The following is a description of a gene set: Reactome Pathway: G alpha (i) signalling events species: Homo sapiens The classical signalling mechanism for G alpha (i) is inhibition of the cAMP dependent pathway through inhibition of adenylate cyclase (Dessauer C W et al. 2002). Decreased production of cAMP from ATP results in decreased activity of cAMP-dependent protein kinases. Other functions of G alpha (i) includes activation of the protein tyrosine kinase c-Src (Ma Y C et al. 2000). Regulator of G-protein Signalling (RGS) proteins can regulate the activity of G alpha (i). part of: GPCR downstream signalling, and this is the list of marker genes: CXCL16, PPBP, CAMK2G, TAS2R39, GNB3, TAS2R1, NMU, GNG13, PRKAR2A, GNB5, RGS3, NMS, PPP3CC, PLCB1, GPER1, SAA1, NPBWR2, GAL, CORT, CCR2, C3, PDE1A, CCL1, ADCY4, GPR37, NPBWR1, CCR1, C5AR1, OPRD1, GNG11, TAS2R3 (NCBI Gene Id 50831), GNAI1, NPY4R, PF4, TAS2R4, TAS2R20, GNB2, PDE1C, GNA14, CCL25, NMUR1, TAS2R10, PPP2R1A, CCR6, ITPR1, GNG4, PDE4B, ADRA2C, CCL13, TAS2R31, C5, GRM2, SSTR2, RGS21, RGS9, GNAS, CXCR4, NPY1R, FPR2, GALR2, PRKCG, APP, MCHR2, CCL19, OPN1LW, GPR17 (G protein-coupled receptor 17), CAMK4, PLCB3, GNA11, OPN1SW, GNG8, GPR31, GPR55, CREB1, PENK (proenkephalin), ITPR3, TAS2R16, GNAT1, SSTR1, PRKAR1A, OXGR1, HTR5A, PPP2R5D, GNAI3, AGTR2 (angiotensin II receptor type 2), SSTR3, GRM6, PRKAR1B, FPR1, OPRM1, PPP3CB, LPAR1, TAS2R50, GABBR1, PLCB2, BDKRB1, PRKCA, LPAR3, MTNR1B, S1PR4, CXCR3, RGS19, PDE1B, CALM1, HTR1F, ANXA1, PPY, CCL21, RGS5, RGS16, S1PR5, CXCL12, CXCR5, RGS12, SUCNR1, CX3CL1, SRC, ACKR3 (NCBI Gene Id 57007), PPP2R1B, LPAR5, NBEA, TAS2R45, GNAL, RGS4, HTR1D, GNG10, GRM8, PRKCD, MTNR1A, RGS14, TAS1R3, GPSM2, RGS13, ADCY3, P2RY14, RGS8, CXCR1, NPY, CCL4, RGS17, OPN3, PPP3R1, TAS2R13, SST, RGSL1, PDYN, AGT, RGS22, TAS1R1, ADCY7, PPP1CA, GRK2, TAS2R46, CNR1, CHRM4, CXCL6, SSTR4 (NCBI Gene Id 6754), PRKACB, PRKACA, CCL5 (NCBI Gene Id 8147), INSL5, SSTR5, CCR7, GNAI2, MT-RNR2, CCL27, TAS2R19, CCR4, HCAR1, ADCY8, GPR183, GPR18, TAS1R2, OPRL1, S1PR2, GNB1, CAMK2B, PPP1R1B, TAS2R43, DRD3, GNG2, TAS2R38, GNAT3, CAMK2D, GRM7, CXCL1, PRKX (protein kinase cAMP-dependent X-linked catalytic subunit), PDE4A, TAS2R8, CXCL11, GNB4, ITPR2, FPR3, RHO, PNOC, TAS2R14, OXER1, APLN, HRH4 (histamine receptor H4), RGS6, CAMK2A, RRH, TAS2R60, CXCL8, POMC, AHCYL1, OPN5, CHRM2, CX3CR1, ADCY2, KNG1, GNAT2, ADCY9, ADRA2B, CAMKK1, RGR, ADRA2A, P2RY12, GNAZ, GNA15, P2RY13, CDK5, GPR37L1, HTR1B (5-hydroxytryptamine receptor 1B), GRM4, NMUR2, GPSM1, S1PR3, CCR3, ADORA3, PDE4D, CAMKK2, HCAR3, PLA2G4A, RGS10, CCR5, LPAR2, CCL23, GALR1, TAS2R9, PRKACG, GNG12, CCL16, TAS2R41, PMCH, NPW, GRM3, PPP2CA, RGS11, RGS7, GNG7, NPB, CCL28, CCR8, PSAP, ADORA1 (adenosine A1 receptor), APLNR, GNG5, CXCL10, NPY5R, GABBR2, PYY, NPY2R, GNAQ, GNGT2, C3AR1, PTGER3, KPNA2, HCAR2, PCP2, HTR1E, CXCL5, CCL20, CASR, CXCL9 (NCBI Gene Id 4283), CCR10, TAS2R40, TAS2R7, PPP3CA, TAS2R30, CXCL2, PPP2CB, CXCR2, ADCY1, TAS2R42, MAPK1, RGS18, CNR2, OPRK1, CXCR6, PLCB4, MCHR1, CXCL13, DRD4, RXFP3, HEBP1, RXFP4, TAS2R5, BDKRB2, GALR3, GPSM3, RGS1, P2RY4, ADCY6, CCL4L1, CXCL3, CCR9, PRKAR2B, PDE4C, OPN1MW, RGS20, PTGDR2 (NCBI Gene Id 9484), GNG3, ADCY5, GNGT1 (G protein subunit gamma transducin 1), RLN3